Given this list of marker genes MBLAC1, PRORP, RTCB, POP4, AGO3, POLR1C, APEX1 (NCBI Gene Id 328), TRMT12, AARSD1, TUT7, DDX54, CPSF3, DDX42, IGHMBP2, POLR3A, ALKBH8, DIMT1, SARS2, GARS1, TYW3, AQR, CARS1, EIF4A1, CNOT8 (NCBI Gene Id 9337), ERI2, EXOSC5, TMT1A, VARS1, RTCA, TSEN34, BUD23, SUPV3L1, POP1, VARS2, FARSA, PRORSD1P, AARS2, DHX32, DALRD3, POLRMT, WARS2, DDX50, AGO4, TMBIM6, NARS2, AGO2, TRMT2A, MOV10, GATC, MTREX, DTD1 (NCBI Gene Id 92675), NOB1, TRPT1, RNASE11, EXD2, QTRT2, NUDT16, DXO, DDX1, QARS1, RARS1, TSR3, DROSHA, ISG20L2, TRMT5, FMR1, DHX8, TRMU, PTRH1, EMG1, XRN1, TRMT10A, POP7, ANG, DHX16 (NCBI Gene Id 8449), FARSB, ISG20, TRMT61A, RPP21, AARS1, DHX40, RNASET2, POLR3F (RNA polymerase III subunit F), RPP40, POLR2H, AGO1, NSUN5, TSNAX, NSUN3, THUMPD2, ELAC1, DDX3Y, METTL16, PIWIL4, DHX57, WARS1, TRMT44, MARS1, TRMT2B, MRPL58, TRMT61B, ABCE1, PPP1R8, SPOUT1, TRMT9B, ALKBH1, GGT5, CDKAL1, RNASEH2A, UPF1, PARS2, MRM1, RNASEL, THG1L, EPRS1, SEPSECS, NUDT16L1, METTL25B, DDX52, DDX6, RNGTT, PUSL1, PUS7, RPP14, NOCT, TYW5, DHX34, TFB2M, POLR2I, RIGI, TFB1M, FBL, EARS2, POLR2K, FTSJ1 (FtsJ RNA 2'-O-methyltransferase 1), RIDA, IARS1, DUS1L, MRM3, METTL2B, POLR3G, POLR2A, RPP30, CWF19L1, TUT4, RNASE4, NSUN5P2, YARS1, DHX37, MARS2, TYW1, EXOSC3, POLR3C, TRMT13, RNASE1, N4BP1 (NCBI Gene Id 9683), UBE3D, USB1, INTS11, EIF4H, DDX19A, PCIF1, DDX3X, DDX47, THUMPD3, DHX36, PNPT1, DARS2, TGS1, TRNT1, EXOG, DDX23, LRRC47, NSUN6, PIWIL1, DHX58, TRMT1, DDX19B, DDX25, FTO, ALKBH5, METTL1, METTL15, PIF1, LARS1, CNOT1, RNASE12, EIF4A2, LACTB2, ALKBH3, YARS2, POLR2E, POLR2F, IFIH1, DCPS, PDE12 (phosphodiesterase 12), DDX39A, FBLL1, PLD6, G3BP1, RNMT, BCDIN3D (NCBI Gene Id 144233), MED20, DIS3L2, DHX30, CNOT6, MRPL44, RNASEH1, ZCCHC4, DDX43, DTWD1, DDX55, SMG6, MRM2, RNASE8 (NCBI Gene Id 122665), SLU7, NT5C3A, DUS3L, POLR2J2, SAMHD1, POLR1A, POLR3B, DDX59, TRMT11, BRAT1, RNH1, GATB, EXOSC1, KHNYN, TDP2, PAN2, MOV10L1, PIWIL3, DIS3, TRMT1L, DTD2, DIS3L, SLFN13, IARS2, SARS1, ETF1, POLR3K, DDX4, PUS3, ENDOU, POLR2L, NOP2, GTDC1, SLFN14, RPPH1, DCP2, ZC3H12A, CNOT2, POLR1D, DDX60 (NCBI Gene Id 55601), MARF1, MED21, TOE1, FARS2, TARBP1, DDX56, POLR2J, TRMT10C, CMTR2, ERN1, EXOSC8, XRN2, EXOSC10, DDX46, POLR1B, POLR3H, CRCP, SKIC2, CDK5RAP1, B3GNTL1, DDX11L8, EXO1, DHX15, RNASE7, ERI3, HARS1, MTFMT, HENMT1, TUT1, FXR1, ELAC2, DDX10, TARS2, TERT, DHX29, DDX31, EXOSC2, TRIT1, DHX35, FTSJ3, DDX21, LARS2, METTL4, RAD54B, FEN1, METTL8, PRIMPOL, DDX12P, GGT1, PIWIL2, ERN2, PNLDC1, YBEY, UVSSA (UV stimulated scaffold protein A), DUS4L, NYNRIN, DHX33, POLR1H, RPP38, NSUN2, PAN3, ZC3H12C, TOP3B, FANCM, LCMT2, METTL2A, SNRNP200 (small nuclear ribonucleoprotein U5 subunit 200), POLR2B, RARS2, NSUN5P1, DDX24, DDX53, TARS3, DDX20, METTL15P1, EXOSC6, METTL6, DTWD2, NSUN4, PUS10, POLR2C, DUS2, DICER1, CNOT6L, RNASE3, HARS2, METTL14, BRIP1, MEPCE, DDX41, EXOSC9, EXOSC4, RNASE2, PRIM1, TRUB2, CMTR1, NARS1, ZC3H12D, CNOT7, TRUB1, EIF4B, ENDOG, DDX60L, RPP25, HELZ2, METTL5, TRMT10B, PUS1, EIF4A3, TRDMT1, TRMO, POLR2J3, FDXACB1, DDX51, METTL3, DBR1, DDX39B, TDRD12, CARS2, ZC3H12B, RNASE13, EXOSC7, AZGP1, NUDT12, KARS1, REXO2, JMJD6, RCL1, DDX17, DARS1, ERI1, MYG1, DDX18, QRSL1, RNASE9, RPUSD4 (NCBI Gene Id 84881), QTRT1, TARS1, RLIG1, PSTK (phosphoseryl-tRNA kinase), GTPBP3, PTRHD1, DDX27, DDX28, DHX38, SND1, POP5, PRIM2, ANKZF1, TDRD9, SLFN12, TSEN2, ENDOV, RNASEK (NCBI Gene Id 440400), DDX5, PTRH2, DHX9, PARN, RNASE10, TYW1B, MTO1, RNASE6, DDX49, YTHDC2, here is a description of the gene set: species: Homo sapiens Catalytic activity that acts to modify RNA. Human Gene Set: GOMF_CATALYTIC_ACTIVITY_ACTING_ON_RNA